Given this list of marker genes AGPS, PCDH17, PIDD1, FZD8, DUSP10, ZNF503, HOXA5, B3GNT5, IFIT3, IFIT1, DUXAP8, CROT, TBX1, ZMYND8, NSUN5, MB21D2, SMIM3, LMO2, MT1F, STAT1, RASSF10, TNK2, FOXC1, ZNF395, FOXP1, SMAD7, RHOBTB3, PPAN, LYPD1, PHLDB2, ADORA2A (NCBI Gene Id 135), SHISA3, CYRIA, SH2D3C (SH2 domain containing 3C), GBP1, KNOP1, NYNRIN, HEY2, SOX4, PRSS23-AS1, EXOSC4, AURKB, EEIG2, STK38L, SORBS2, PGRMC2, PLIN2, PDGFB, RPRD1A, NSUN5P1, C1QTNF6, HRCT1, ENSG00000291006, TCIM, GRAP, DUSP23, RUNX1T1, SESN3, GJA5, RAPGEF5, ATOH8, LIPG, GXYLT2, TFAP2A, CRISPLD1, FLRT2, OXLD1, JADE1, MECOM, KANK2, ARL4A, MGARP, TBX18, ACKR3, IFIT5, TMT1A, FRMD3, EVI2B, PPP1R3C, SPAAR, here is a description of the gene set: from publication Gargalovic PS, Imura M, Zhang B, Gharavi NM, Clark MJ, Pagnon J, Yang WP, He A, Truong A, Patel S, Nelson SF, Horvath S, Berliner JA, Kirchgessner TG, Lusis AJ (PMID 16912112) Genes from the grey module which are dn-regulated in HAEC cells (primary aortic endothelium) after exposure to the oxidized 1-palmitoyl-2-arachidonyl-sn-3-glycerophosphorylcholine (oxPAPC). studied in species Homo sapiens Human Gene Set: GARGALOVIC_RESPONSE_TO_OXIDIZED_PHOSPHOLIPIDS_GREY_DN Oxidized phospholipids are thought to promote atherogenesis by stimulating endothelial cells (ECs) to produce inflammatory cytokines, such as IL-8. In studies with mouse models, we previously demonstrated that genetic variation in inflammatory responses of endothelial cells to oxidized lipids contributes importantly to atherosclerosis susceptibility. We now show that similar variations occur in cultured aortic ECs derived from multiple heart transplant donors. These variations were stably maintained between passages and, thus, reflect either genetic or epigenetic regulatory differences. Expression array analysis of aortic EC cultures derived from 12 individuals revealed that >genes were regulated by oxidized phospholipids. We have used the observed variations in the sampled population to construct a gene coexpression network comprised of 15 modules of highly connected genes. We show that several identified modules are significantly enriched in genes for known pathways and confirm a module enriched for unfolded protein response (UPR) genes using siRNA and the UPR inducer tunicamycin. On the basis of the constructed network, we predicted that a gene of unknown function (MGC4504) present in the UPR module is a target for UPR transcriptional activator ATF4. Our data also indicate that IL-8 is present in the UPR module and is regulated, in part, by the UPR. We validate these by using siRNA. In conclusion, we show that interindividual variability can be used to group genes into pathways and predict gene-gene regulatory relationships, thus identifying targets potentially involved in susceptibility to common diseases such as atherosclerosis.